The following is a description of a gene set: Human Gene Set: MIR6742_3P studied in species Homo sapiens from publication Chen Y, Wang X (PMID 31504780) Genes predicted to be targets of miRBase v22 microRNA hsa-miR-6742-3p in miRDB v6.0 with MirTarget v4 prediction scores > 80 (high confidence targets)., and this is the list of marker genes: PPP2R2C, SEC14L4, ARID5B, PSMC4, THBS3 (NCBI Gene Id 7059), NCDN, RIT1, ERF, CNTNAP1, MTCL2, RPL13, MAU2, USP31, KRT72, AARS2, C1QTNF6, ARRB1, OSCAR, FOXC1, DNAAF11, AIPL1, SHISA7, SLC45A3, VPS53, SLC26A9, NFKBIZ, PICALM, TDP1, BBS1, CYTH3, GFAP, TFB1M, ELAC2, FAM168A, KLK4, TNFSF10, MBTD1, RNF2, ZNFX1, BACE1, PLXDC2, MOSMO, BDNF, PHIP, ITGA5, KCNAB1, DTNB, TBC1D16, NIPAL3, TNFRSF9, DPYSL5, GALNT11, ALPK3, PIP4K2B, INSYN1, PLEKHG4B, ALS2CL, RAB5B, MYOCD, CEP44, MTF1, ATXN7L3, SLC23A2, DCTN5, EPHA5, RASD1, ASH1L, FGF11, CREB3L1, PAPPA, MAK16, BEND3, CYTL1, PTPRT, INHBA, GID4, PRAF2, LASP1, KPNA6, SMC3, AHCYL2, TGFBR1, PLCXD2, MAN2B2, WDR47, GTF2A1, SOX10, OPN4, TWIST2, BTRC, DLGAP3, ELMO2, RPS6KA1, EPDR1, PSMF1, HAUS2, EGFR, STK4, SPTLC2